Given this list of marker genes Pus7, Hnrnpu, Mtch2, Mir154, Prkdc, Fzd1, Mta1, Rest, Nr5a2, Trim6, Rbm24, Mir34a, Nanog, Nkx2-5, Mir100, Tgfbr2, Hes1, Mta2, Crxos, Jag1, Hdac1, Lbh, Nsun2 (NOL1/NOP2/Sun domain family member 2), Nfe2l2, Gatad2a, Men1, Yap1, Mta3, Hes5, Ythdf2, Sox6, Rbbp4, Dhx36, Tmsb4x, Esrrb, Tacstd2, Stat3, Hdac2, Mbd3, Ociad1, Smyd5, Notch1, Rbbp7, Ap2a2, Zfp36, Wnt3, Ncoa3, Tbx5, Mir137, Ezh2, N4bp2l2, Cdk12, Hoxb4, Sirt6, Nelfb, Setd1a, Bmpr1a, Foxc1, Sp7, Vsir, Dicer1, Mir125a, Tead2, Cdk13, Kat5, Ltbp3, Ccnk, Zfp36l2, Pdgfra, Tgfb2, Ptn, Sox17, Fgf2, Hspa9, Prdm4, Sox5, Prickle1, Pwp1, Mettl3, Kdm3a, Nudt21, Eif2ak2, Sox9, Gsk3b, Bbs12, Tbx3, Cdk6, Chd4, Tcf15, Kdm4c, Gatad2b, Nr6a1, Slc4a11, here is a description of the gene set: species: Mus musculus Any process that modulates the frequency, rate or extent of stem cell differentiation. Mouse Gene Set: GOBP_REGULATION_OF_STEM_CELL_DIFFERENTIATION